Given this list of marker genes Ptpmt1, Them5, Mecp2, Pla2g6, Pnpla8, Slc27a1 (solute carrier family 27 (fatty acid transporter), member 1), Tamm41 (NCBI Gene Id 68971), Lclat1, Spata18, Hadha, Plscr3, Tafazzin, Crls1, Pla2g5, Phb2, Pgs1, Dnajc19, here is a description of the gene set: species: Mus musculus Mouse Gene Set: GOBP_CARDIOLIPIN_METABOLIC_PROCESS The chemical reactions and pathways involving cardiolipin, 1,3-bis(3-phosphatidyl)glycerol.